Given this list of marker genes Cxcl10, Fgf1 (NCBI Gene Id 14164), Lcn2, Adamts12, Itgax, Foxp1, Alox12, here is a description of the gene set: Any process that modulates the frequency, rate or extent of endothelial tube morphogenesis. studied in species Mus musculus Mouse Gene Set: GOBP_REGULATION_OF_ENDOTHELIAL_TUBE_MORPHOGENESIS